The following is a description of a gene set: Mouse Gene Set: GOBP_GRANULOCYTE_DIFFERENTIATION studied in species Mus musculus The process in which a myeloid precursor cell acquires the specialized features of a granulocyte. Granulocytes are a class of leukocytes characterized by the presence of granules in their cytoplasm. These cells are active in allergic immune reactions such as arthritic inflammation and rashes. This class includes basophils, eosinophils and neutrophils., and this is the list of marker genes: Gata2, Il5, Fosl2, Gata1, Fam3c, Cebpa, Cul4a, Cited2, L3mbtl3, Srp54c, Evi2, Jagn1, Srp54b, Zfpm1, Lbr, Lef1, Inpp5d, Spi1, Il25, Tesc, Kdm1a, Hax1, Srp54a, Ap3b1, C1qc (complement component 1, q subcomponent, C chain), Il17c, Ikzf1, Ceacam1, Bap1 (Brca1 associated protein 1), Mir223, Clpb (ClpB caseinolytic peptidase B), Trib1, Adipoq, Cebpe, Csf3, Nkap, Rbp1, Csf2, Lyn, Cbfa2t3 (NCBI Gene Id 320906), Tal1, Runx1, Stat5a, Zbtb46, Prdm16, Evi2b, Tescl, Rara, Hcls1, Dhrs7b, Gfi1b, Sp3, Fasn